Given this list of marker genes NPAS2, GRP, PRKAR1B, MEF2C, PENK, CRH, GRPR (NCBI Gene Id 2925), UCN, here is a description of the gene set: Human Gene Set: GOBP_POSITIVE_REGULATION_OF_FEAR_RESPONSE species: Homo sapiens Any process that activates or increases the frequency, rate or extent of fear response.